Given this list of marker genes UMODL1, CDCA3, STXBP2, NPTX1 (NCBI Gene Id 4884), SIPA1, GRHL3, TAAR3P, NEK2, LDAF1, MARCHF4, CD163L1, HTR2B, DBI, SGO1, FOXO3, WAS, ANGPTL2, ALKBH7, FBXO25, SLC28A3, SMPDL3B, ELF4, STEAP2, NBEAL2, TRIM14, NPHP4, MBOAT1, SLC25A11, TSC1, EDEM1, POC1A, CORO1A, INPP5F, ATP6V0A2, CTNS, PHLPP2, RPRD2, RNF148, TTC12, MAP3K5, HIPK1, ESCO2, CENPN, NPSR1, DOCK2, NAA60, CLIP3, ANKRD26, RANBP10, MVB12A, PKP3, SPRR2D, TSPAN13, PDE7A, IL6R, GAB2, PLD3, UBE2V1, HEPACAM, PEX5, VGLL4, PCDHB16, P2RX7, DUSP8, TMEM86A, DUSP18, OTULINL, MAMDC4, DPP4, GABARAPL1, PDLIM7, SMPD1, GALNT12, LIX1L (NCBI Gene Id 128077), SLC2A12, IDH2, PRKD2, GRK2, ASXL2 (ASXL transcriptional regulator 2), TLE4, ENTPD5, FAM168A, SLC43A2, ANXA11, BUB1B, DYRK1B, GPR107, HMG20B (high mobility group 20B), MR1, GATD3, KIF23, LCA5, ITGB1, PIMREG, HASPIN, STX3, KIF3A, ITM2B, GBA1, RIT1, GCC2, CEP97, RHOU, NR2C2, HECTD3, FOXO4, MIA2, YIPF3, PARP16, CMTM4, MATN2 (matrilin 2), LEPROT, CDC25C, PLEKHG3, ANKRD54 (ankyrin repeat domain 54), ARPP21, ARAP1, CDKN1B, NEK3, ECT2, PRKCQ, CAVIN2, GPR52, FCHO2, WIPI1, RAB19, STING1, CCDC125, MSL3, RNF216, CYTH4, ATOSA, EXOC6B, OSBPL7, ZFP41, EPHB6, DNASE1L1, GRK6, IRF2BP2, PROC, TST, ACSS1, MED12L, NCAPD3 (NCBI Gene Id 23310), ITPRIPL2, WRN, here is a description of the gene set: This array analysis is to study developmental time course of the regulation of target messages’ expression during culture of murine neutrophils versus miR-223 null neutrophils. Culture media was SILAC-IMDM for MS analysis. from publication Baek D, Villén J, Shin C, Camargo FD, Gygi SP, Bartel DP (PMID 18668037) species: Homo sapiens Genes down-regulated in 8 day cultures of bone marrow progenitors: wildtype versus MIR223 knockout. Human Gene Set: GSE12003_MIR223_KO_VS_WT_BM_PROGENITOR_8D_CULTURE_DN